The following is a description of a gene set: Human Gene Set: GOMF_CELL_ADHESION_MOLECULE_BINDING Binding to a cell adhesion molecule. species: Homo sapiens, and this is the list of marker genes: F11R (NCBI Gene Id 50848), MRE11, SYK, RPL34, ILK, TES, SELP, YWHAB, HSP90AB1, PFN1, ECM2, JAM2, ISG15, NUMB, NLGN4Y, SCRIB, SPTBN2, PRKCA, ERC1, PALLD, STXBP6, NTNG1, PTPRM, ITGA9, LAD1, SEPTIN7, CDC42EP1, HCFC1, CD177, SNX1, KTN1, ITGA3, EIF4H, CTNNA2, FGB, DAB2IP, PTPRF, LRP12, ITGBL1, MICALL1 (MICAL like 1), ACTN2, SND1, DSCAML1, EPCAM, THBS4, SNX9, FASN, FSCN1, CLSTN3 (calsyntenin 3), HSPA8, EVPL, CTNND1, ADAM10, PKP3, NRG1, DSG2, FGG, JAM3, ARHGEF16, KRT18, NCK1, CLDN3, TSPAN4, PDXDC1, ANLN, ANGPTL3, ITGB5, CRKL, ESYT2, LASP1, CD47 (CD47 molecule), CDH8, KIRREL1, RPS26, PLEC, UBFD1, HDLBP, S1PR3, ITGAD, LGALS8, BCAM, COMP, ADAMTS13, RANBP1, GPRC5A, ANXA7, ITGA4, GOLGA3, ITGB1BP1, GIPC1, RDX, TJP3, FN1, PTPRB, RPSA2, TJP1, DDX3X, MFGE8, GAPVD1 (NCBI Gene Id 26130), THBS1, LAMB1, MARK2, LCP1, ABI1, NECTIN2, TWF2, EMD, TMPO, MPP7, PLPP3, PAK6, CLDN19, ARGLU1, SRC, RPL23A, NLGN4X, CLIC1, MYO1B, DSP, ARHGAP18, FERMT2, ITGB1, NUDC, FNBP1L, ADAM11, MMP24, GFAP, ARFIP2, BZW1, RACK1, CXCL12, NFASC, SPP1 (NCBI Gene Id 6696), YWHAE, EMILIN1, TLN2, TWF1, CCS, ARVCF, SLC3A2, CNTN6, PLIN3, FERMT3, ACTN4, NRXN2, CDH3, S100A11, IL1B, ADGRL3, PDLIM5, IBSP, CALR, ADAMTS8, CHMP5, FAP, CCT8, BSG, TENM2, SLC6A4, EHD4, MB21D2, ICAM2, ALDOA, ITGA11, COBLL1, PICALM (phosphatidylinositol binding clathrin assembly protein), ADGRL1, CD151, CCN2, NPNT, AGER, PPIA, PCMT1, PUF60, FRMD5, PCBP1, CD40LG, MAPRE1, SCYL1, UTRN, H3C8, ITGA2B, RARS1, ATXN2L, NLGN3, ITGB7, LARP1 (La ribonucleoprotein 1, translational regulator), THY1, ADAM22, CAST, SLC14A2, DHX29, COL3A1, RPL29, ACVR1, PTPN6, MCAM, PTPN2, PSEN1, CDH10, ITGA5, ARHGAP1, YWHAZ, LYN, CD2AP, CEMIP2, ZC3H15, H3C4, PKP4, TENM4, P2RX4, PTPN11, EPS8L1, CD1D, NINJ1, EGFL6, KLC2, ITGA2, PSMB6, VWF, CCN5, EEF1G, ADAM15, CD46, LTBP4, CBL, FBLN5, BAG3, EIF4G2, IGF1 (NCBI Gene Id 3479), IGF2, ITGB1BP2, RPL6, EPS8L2 (EPS8 signaling adaptor L2), NHERF2, CNN2, TAGLN2, LDHA, GIGYF2, CDH5, H1-10, STX5, ADAM2, ITGAL, PRDX1, RPL24, TBC1D2, PTPRD, TNN (tenascin N), CD200, AFDN, VAPA, CDH24, PKP2, LRRC59, LAMA5, P4HB, ADAMTS5, PAK2, TMIGD1, ATIC, RAB11B, CDH26, MADCAM1, NRXN3, CTNNB1, TNC, LIMA1, PTPRH, CKAP5, MSN (moesin), CCN6, FBLN1, EIF2A, ITGB3, DST, CDH23, SH3GLB1, ADD1, CHMP4B, H3C3, H3C12, FCER2, RUVBL1, PROM1 (prominin 1), RAB10, SERBP1, NPHS1 (NCBI Gene Id 8183), EDIL3, ANXA1, DIAPH3 (NCBI Gene Id 81624), AHSA1, ITGA1, CASR, ITGAE, KDR (NCBI Gene Id 3791), HSPG2, ANXA2, VASN (NCBI Gene Id 337957, vasorin), CDH22, TENM3, COL4A3, CCN1, PTPRZ1, ITGB8, BMPR2, APP, CD81, BAIAP2L1, ITGA7, CNTN5, JUP, EMB, CAPG, SWAP70, CGN, CDH19, RPS2, PTN, ASAP1, SIRPA, SHTN1, DDX6, PTPRT, DOCK9, SH3GL1, DMP1, UNC45A, IST1, CIB2, H3C6, NECTIN3, ROBO3, SH3GLB2, TXNDC9, HSPA5, H3C1, LRRC4C, MMP14, NLGN2, FGF2, CDH4, CDH9, EHD1, OLFM4, AHNAK, TNKS1BP1, PHLDB2, OLA1, KIRREL3, RAB1A, CTTN, CHMP2B, ITGAX, GLDN, MYPN, EZR, ITGA6 (NCBI Gene Id 3655), NIBAN2, NDRG1, CDH12, PKP1, ITGAM, SVEP1, WASF2, ITGB2, ADAM23, MRTFB, CDH2, RPL14, YKT6, PLCB3, FLNB, EPS15L1, RTN4, CDHR2, ESM1, TMOD3, GPNMB, ITGB4, H3C11, CDH6, GCN1, IGSF9, GOLGA2, RPSA, DBN1 (drebrin 1), DSCAM, MPRIP, CPE, ENO1, CCN3, CDH20, CCNB2, KIF5B, PAICS, ICAM4, H3C2, HNRNPK, CDH18, CNTN1, CDH13, CTNNA3 (catenin alpha 3), TNXB, PKM, PLXNB3 (plexin B3), TJP2, H3C7 (NCBI Gene Id 8968), CDH1, CDHR5, PVR, CNTN2, CDH17, CDH7, TLN1, CDHR3, NOP56, CX3CL1, EPHA2, ADAM17, MYH9, TRIM25, MACF1, CNN3, APC, PTPN1, NECTIN1, CC2D1A, PPFIBP1, FXYD5, RANGAP1, TBC1D10A, ADAM9, ITGB6, LYPLA2, ADAM8 (ADAM metallopeptidase domain 8), SEMA7A, RPL15, ICAM1, CTNNA1, ROBO4, S100P, PRDX6, PARK7 (Parkinsonism associated deglycase), SLK, ITGA8, DLG1, CDH11, NISCH, ANK3, HSPA1A, IQGAP1, UBAP2, NF2, ITGA10, SNX5, CCN4, STAT1, SFRP2, FLNA, CAPZA1, EIF3E, PAK4, CDH15, NEXN, H3C10, ICAM5 (intercellular adhesion molecule 5), PARVA, MIP, LAMB2, NOTCH3, SPTAN1, PPP1CA, ZC3HAV1, TENM1, NEO1, EEF2, CIP2A, VTN, CTNNAL1, EIF2S3, CNTN4, CD9, EPS15, VASP, POSTN, NRCAM, PTPRO, COL5A1, RAN, FERMT1, CORO1B, CSNK1D, KIRREL2, SEPTIN2, EGFR, CTNND2, NLGN1, PPME1, ACTN3, FGF1, DSC2, ITGAV, DBNL, NRXN1 (neurexin 1), TRIM29, EXOC3, USO1, PTK2, USP8, STK38, ACTN1, CXADR, GLOD4, PDLIM1, PACSIN2, CD226, PPL (periplakin), RPL7A, FMNL2, CALD1, SFN, FBN1, EIF5, NPTN, EFHD2, VCAM1, HMGB1, RSL1D1, ABCF3, ICAM3, CNGA3, GFRA1, BAIAP2, JAML, COL16A1 (NCBI Gene Id 1307), CLINT1, S1PR2, SEPTIN9, PPP1R13L, LILRB2, TGFBI, SPTBN1, VCL, EPN2, TRPC4, PI4KA, FGA, ESAM, SNX2, CDK5R1, IZUMO1, DNAJB1, BZW2, PFKP, LRRFIP1, TSPAN8, CAPZB, VAPB, VSIG10L2, VSIG10, PTPRJ, IDH1, STK24, PKN2, EEF1D, EMP2, DCHS1